The following is a description of a gene set: species: Mus musculus Mouse Gene Set: GOBP_REGULATION_OF_CLATHRIN_DEPENDENT_ENDOCYTOSIS Any process that modulates the frequency, rate or extent of clathrin-mediated endocytosis., and this is the list of marker genes: Wasl (NCBI Gene Id 73178), Dab2, Dnajc6, Ccdc32, Dnm2, Sh3gl2, Neu3, Dgkd, Aak1, Snap91, Sh3gl3, Bmp2k, Tnk2, Hip1r, Unc119, Smap1, Ush1g, Syt11 (synaptotagmin XI), Ubqln2